The following is a description of a gene set: studied in species Mus musculus from publication Bedogni F, Hevner RF (PMID 34321999) Mouse Gene Set: HEVNER_CORTEX_ROSTRAL_VENTRICULAR_ZONE Genes expressed at higher levels in rostral regions beginning in the ventricular zone, in some cases extending into the subventricular zone, intermediate zone, and cortical plate of embryonic day 14.5 mouse cortex., and this is the list of marker genes: Elk3 (ELK3, member of ETS oncogene family), Mt3, Rlbp1, Sema3a, Ddah1, Smoc1, Etv5, Lipg, Lima1, Aldh1l1, Phf19, Ntn4, Abhd4, Lmcd1, Mlc1, Pbx3, Etv1, Rgcc, Vit, Mest, Ccnd1, Mir99ahg, Rai14, Pax6, Fgfbp3, Fam210b, Dct, Shc3, Acss1, Actr3b